The following is a description of a gene set: studied in species Mus musculus from publication Yevshin I, Sharipov R, Kolmykov S, Kondrakhin Y, Kolpakov F (PMID 30445619) Mouse Gene Set: GM6710_GM14391_UNIPROT_A2ART0_UNREVIEWED_TARGET_GENES, and this is the list of marker genes: Pdpk1, Ctbp2, Tm4sf5, Zfp212, Dhx16, Mir6405, Was, Hipk1 (NCBI Gene Id 68849), Sntb2, Gemin2, Dohh, Zfp809, Saal1 (serum amyloid A-like 1), Zfta, Lst1, Ankrd40, Pias3, Cenatac, Snrpb, Gm2990, Srebf1